Given this list of marker genes OXT, CARTPT, ABAT, CHRNA4, GRK2, DRD3, CHRNA6 (cholinergic receptor nicotinic alpha 6 subunit), GRM2, CHGA, DTNBP1, STX1A, KCNB1, ADORA3, ADRA2C, CXCL12, CHRNB2, OPRK1, PINK1, DRD2, GDNF, ADRA2B, SNCA, ADRA2A, KCNA2 (potassium voltage-gated channel subfamily A member 2), SYT1, HTR2A, PRKN, FFAR3, P2RY1, GABBR1, CRH, SNCG, NPY2R, GHSR, SDHD, SYT11, FGF20, SYT4, ADORA2A, here is a description of the gene set: Human Gene Set: GOBP_REGULATION_OF_CATECHOLAMINE_SECRETION Any process that modulates the frequency, rate or extent of the regulated release of catecholamines. species: Homo sapiens